The following is a description of a gene set: species: Mus musculus part of: Initial triggering of complement electronically inferred by orthology from the curated human pathway Reactome Pathway: Creation of C4 and C2 activators This event has been computationally inferred from an event that has been demonstrated in another species.<p>The inference is based on the homology mapping from PANTHER. Briefly, reactions for which all involved PhysicalEntities (in input, output and catalyst) have a mapped orthologue/paralogue (for complexes at least 75% of components must have a mapping) are inferred to the other species., and this is the list of marker genes: C1qc, Masp2, Igll1, Mbl2, Fcna, C1ra, C1s2, Colec10, Fcnb, Colec11, C1qa, Masp1, C1qb